Given this list of marker genes IDS, EVC2, COL9A3, FGD1, PDE4D, CANT1, CHST11, CAMK2G (NCBI Gene Id 818), PCGF2, EVC, DOCK3, RTTN, COL9A2, AGO1, MATN3, COL10A1, SMARCA2, ZMYM3, COMP, LBR, COL1A1 (NCBI Gene Id 4970), here is a description of the gene set: A mild degree of short stature, more than -2 SD but not more than -3 SD from mean corrected for age and sex. Human Gene Set: HP_MILD_SHORT_STATURE studied in species Homo sapiens Mild short stature